The following is a description of a gene set: studied in species Homo sapiens Human Gene Set: GOCC_CILIARY_BASE Area of the cilium (also called flagellum) where the basal body and the axoneme are anchored to the plasma membrane. The ciliary base encompasses the distal part of the basal body, transition fibers and transition zone and is structurally and functionally very distinct from the rest of the cilium. In this area proteins are sorted and filtered before entering the cilium, and many ciliary proteins localize specifically to this area., and this is the list of marker genes: KCNF1, NPHP3, CIBAR1, PRKAR1A, PRKAR2B, SUFU, TTBK2, DNALI1, GLI2, PRKACG, CPLANE2, CILK1, PRKAR2A, IFT20, CLCN4, CFAP418, CFAP36, IFT88, PRKACA, SPACA9, IFT57, FANK1, MOK, GLI3, NEK8, PRKAR1B, NPHP4, MAGI2, PRKACB, DISC1, TRAF3IP1, IFT56, CFAP144P1, ENKD1, RAB8A, DYNC2I1, KCNJ10, USH1G, ODAD2, IFT52, CFAP144, KCNQ1, TULP3, DZIP1, DYNLT2B, C11orf97, GLI1, CEP126, CLUAP1